Given this list of marker genes ITGA5, AMELY, ATOSB, GLRX, S100A8, LRP3, NTNG1, P2RX1, RHOD, CCND2 (cyclin D2), N4BP2L1, ALDH1A3, PDE2A, EMP3, RBMS3, RAMP1, PRG2, NME3, SERPINE1, LTBR, HYI, GADD45G, CPN2, ALAS2, FGL1, WWC1, TSPAN8, SCAMP5, RRP9, CD6, CCL2, FBP1, ITIH2, CCN5, SERPINA6, ALB, CHGA (NCBI Gene Id 1113), LDLR, MYH2, ETFB, AOC1, STOML1, TNFRSF1B, UGDH, FXYD1, OCLN, LRIT1, WFDC2, DLC1, APCS, PLK3, PRSS8, IVD, HAP1, MYRF, ADH1C, BCKDK, PYGL, SHMT1, FGB, LAIR1, PHYHIP, ITGA10, PDGFRA, JAK3, AQP1, EPAS1, COL1A2, PEG3, ECI1, SLC37A4, COL3A1, CXCL12, AKR1C3, ALDH3A2, PROX1, ADAM19, EFS, GRM2, SLC22A18AS, FGFR4, NR4A1, LECT2, PLIN2, NRGN, GSTT1, CLDN10, PALM, PTPRN, ELL2, S1PR4 (sphingosine-1-phosphate receptor 4), AANAT, TM4SF4, RECQL5, CDK18, MME, NR1D1, SRPK3, ABCC3, DNM2, RAC2, GSTM1, APOC2, SLC7A4, MAL (NCBI Gene Id 4118), TRPC4AP, NECTIN2 (nectin cell adhesion molecule 2), SLC7A8, ETS2, DHRS3, SLC22A6, BDH1, GAGE12F, TDO2, PRB4, COL1A1, LTF, QDPR, COX7A1, CYP27A1, HPD, CLEC3B, ANK3, APLP1, MGP, DVL1, DNASE1, COL18A1, NQO1 (NCBI Gene Id 4834), NNAT, CHRNB4, TYR, ACSL6, PLAT, GNG12, PSD4, GMPR, INSIG1, SRGN, KRT14, SPRY1, NCALD, AADAC, NR0B2, CELA2B, TNFRSF14, MYL9, AZGP1, ATP2A3, CYP2C8, XPNPEP2, PAX6, RGN, UGT2B4, MPO, LBP, TM7SF2, CLCNKA, LRP1, IER3, FEV, DPYSL4, SNCG, GPX3, S100A11, GPX2, ECM1, NFKBIB, SIX6, ESR1, SCG5, APOA1, KCNQ3, CST1, ADRA2C, IL7R, GNMT, SV2A, FMO5, GNG7, LLGL2, KCTD17, TCN2, PLCB2, CDR2L, DDC, RBM38, FURIN, EGR1, PDE4C, PPP4R2, TFR2, HPGD, DBP, TRIM29, FPR2, UBE2C, LCE2B, ZIC2, MFAP2, LYPD3, FBN2, TLE2, KCNN4, F2, CD163, UMOD, AQP7, ALPL, APOA4, RBP4, ADIRF, ANPEP, GCHFR, PSG7, MYH11, ATP11A, H3C6, UGT2B15, SLC17A3, AAK1, LCAT, SLC10A1, IGFBP4 (insulin like growth factor binding protein 4), APOC3, CFHR1, PTPRN2, MGLL, CRYAB, CRIM1, TBR1, IL32, CAV2, AMELX (amelogenin X-linked), SLC22A1, CYP3A7, REG1B, ID2B, SCNN1A, ECHS1, HLA-DMA, DHRS2, PNRC1, ACTN1, TNFRSF6B, APEX2, MSX1, PRSS3, GRIK5, CES1, COL6A1, ACR, SHBG, NEBL, GPT, FADS1, PLEC, ICMT, CRYM, HTR4, MYOG, TPM2, TFAP2A, PFKFB2, SELENOP, TGM2, PHLDA2 (NCBI Gene Id 7262), CYP4F12, RNASE3, ASIP, SLC25A1 (solute carrier family 25 member 1), RND1, TBCD, CPB2, ITGA3, AMBP, COL6A3, APOL1, MUC5B, AMY2B, H4C3, APOD, COL2A1, ABCA1, NCF1C, MAT1A, ODF1, GCG, GPC3, GLYAT, CBS, KRT31, CARD10, PCBD1, RAB31, FMO4, DMBT1, SLC6A2, KRT18, CD14, PAX7, PTPRO, BBOX1, ABCA3, CDK5R1, ATP6V0A1, IL1R1, ABAT, UNC13B, SERPINC1 (serpin family C member 1), LCN2, KCND3, RGS10, ECM2, ITIH4 (NCBI Gene Id 3701), FGFR1 (fibroblast growth factor receptor 1), HSPG2, FN1, MSMO1, PRR4, SGCE, EPHX1, HPN, TMSB4Y, ITIH3, GATM, STARD5, PHLDA1, LMO2, TMEM97, DNASE1L3, ABLIM3, IFIT1, PROC, SLCO2B1, TULP1, ALDOB, ENPP1, MYLK, DPP4, HRG, PPL, ITGA2B, PRELID3A, LEFTY1, AGXT, C1QB, ACP5 (acid phosphatase 5, tartrate resistant), NHERF1, ERBB3, RAC3, DTX4, EDA, PGC, CDC20, PLAU, CEACAM3, MMP2, SDC1, APOE, SERPINA3 (NCBI Gene Id 95022), CLDN7, AQP9, KRT4, WNT10B, EXD2, UBE2L6, SLC1A6 (NCBI Gene Id 6511), MPPED1, BAAT, GJB1, VEGFA, CRYZ, TIMP3, PLA2G2A, REG1A, TCF7, DIO1, HBD, ISG15, SSTR2, FOS, PEPD, SNAP25, HGD, HMGCS2, EPHX2, KLK11, GATA2, AMT, KRT7, ADH1B, FGFR3, SYNGR4, LRRC32, SLC7A11, EPB41L3, FAT1, HBZ, PON3 (NCBI Gene Id 94886), ALPG, NNMT, LRCH4, DDIT4, MSLN, TRIB1, NRTN, ASGR2, GRN, FOXO4, ST6GALNAC4, PTH1R, CFD, GOT1, ELN, RCVRN, HOXB2, CD33, L1CAM, GALNS, CITED2, ARHGDIG, DEFB1, MSMB, PSD, CNKSR1 (connector enhancer of kinase suppressor of Ras 1), PFKFB3, XDH, FOLR1, PRSS2, MTHFS, RHBDL1, CRABP1, C7, PPBP, IKBKG, C8B, FAT2, LAPTM5, IGSF1, SYNPO2L, IQGAP2, RAMP2, SLC38A10, ITGA6 (integrin subunit alpha 6), CCN1, BMP1, MAGI1, GPR17, CRLF1, PLPP2, FGA, MAOB, AMACR, ORM2, HMOX2, KIF21B, PLAAT3, TNFRSF10C, DKK4, DSP, SDS, CYB5R1, CYP4A11, IHH, MUC1, ALDH1L1, NFKBIL1, TM4SF1, ZKSCAN3, CFI, BSN, COL5A2, C1S, TSPAN7, GPR3, CP, CDH4, G0S2, PDZK1IP1, BRD4, ALAS1, PPP1R1A, GFPT2, GRK1, SFRP1, CDC42EP1, DRD2, MTHFR, IGFBP1, SLC4A4, SLC17A7, SPP2, THRA, CYP2F1, CYP2A7, ABLIM1, SERPIND1 (serpin family D member 1), HSPA6, GAS1, EGFR, NAAA, C6, APOC1, CCND1, MEF2C, ARG1, CFB, ELAC2, KCNMB1 (potassium calcium-activated channel subfamily M regulatory beta subunit 1), SPP1, SOX9, C8A, TNXB, PEG10, ALDH7A1, SLC18A3, HAAO, APBB1, GCLC (glutamate-cysteine ligase catalytic subunit), TACC2, CX3CL1 (NCBI Gene Id 6376), CKS2, SOD3, COL4A1, HNF1B, KRT86, KNG1, DNAH3, TGFBR2, XK (X-linked Kx blood group antigen, Kell and VPS13A binding protein), REN, CASP2, DTNB, PLCH2, P4HA1, QPCT, RNASE1, IGFBP3, FZR1, ATF5, PCK1 (NCBI Gene Id 5105), COL7A1, PPP6R2, C5, SRPX, SERPINA5, FCGRT, HSD17B6 (hydroxysteroid 17-beta dehydrogenase 6), MARF1, MT1G, ITGB5, CYP2C19, PIP, MST1, LTC4S, GDF15, STX1A, CHI3L2, FADS2, S100A9, PCLAF, DCAF7, LY6D, CTSG, SOX10, ABCC6, ENPEP, TBC1D2B, NEURL1, BCAM, GSTM5, PER1, PCK2, SLC4A1, CD22, CCL7, HPR, SORD (NCBI Gene Id 6652), UBL3, DAPK2, ETV3, DDT, DLK1, ADH1A, LGMN, HCN3, EFNA1, SMOX, IL3RA, ANGPT1, VGF, CYP2J2, SPINK1, FCN2, CFAP410, SORBS2, GYPB, CDA, APC2, HSD11B1, BARX2, GATA1, CCKAR, PAH, RIBC2, COL6A2, CD55, RBP1, AK4, ACKR1 (atypical chemokine receptor 1 (Duffy blood group)), CSF3R, PIM2, DAO, ZBTB20, SRRM2, KIAA0586, ECE2, SST, NFIL3, DNAJB2, SBNO2, IGF1, HSD11B2, CEP135 (centrosomal protein 135), NRG2 (NCBI Gene Id 9542), PIGO, ARFGAP3 (NCBI Gene Id 26286), CHRNB1, UBXN1, CYP4B1, ACOX2, TRPM2, SELE, IL1RN, GADD45B, CREB3L1, RNASE2, HOMER2, HSPBP1, PTP4A3 (protein tyrosine phosphatase 4A3), TGFBI, ITIH1, BMP10, CCL15, CDH16, YPEL1, PAEP, LDOC1, POU2F2, CRYAA, FAM107A (NCBI Gene Id 50803), FKBP1B, TBX5, VTN, ATP4A, PAX4, UGT2B7, HBEGF, ASGR1, NECAB3, RBMXL2, TIMM17B, FBXL7, CHST3, CST7 (NCBI Gene Id 8530), HYAL1, LAMB2, ADM, CLDN8, SLC16A4, CPS1, EFNA2, C2, IL2RG, APOB, IFI27, RARRES2 (retinoic acid receptor responder 2), FAAH, GNE, SLC2A3, CCNF, AHSG, RIMS2, HP, TM4SF5, NUPR1, DRD3, LIF, IGHG3, SFTPC, AKR1C1, ALDH1A1, RNF167, TCL1A, ZYX (zyxin), INHBC, HSPA2, PTTG1, LGR5, TFF3 (NCBI Gene Id 7033, trefoil factor 3), TRIM15, CYP2E1, LY6G6C, FLT1, PNOC, PINK1, ST6GAL1, EPOR, KRT5, BLVRB, DPH2, FST, CLDN9, KCNJ4, WDR7, TRIM16, MCM2, IGF2, APOC4, AKR7A3, APOH (NCBI Gene Id 350), CYP2B6, FMO3, ENTPD2, SERPINF2, TNFSF10, ATP9A, PRF1, STAB1, FETUB, S100A4, PLG, SIM2, SCN4A, IVL, CDH1, RHOB, ENPP2, ACSL1, JUNB, AGT, GCH1, CFP, SLC7A7, LGALS4, SLPI, VSIG4, IL4R, UCN, C4BPB, GC, GSTA2, IGFBP2, SEZ6L, TRAPPC6A, FABP1 (fatty acid binding protein 1), CA12, HOXB1, PROM1, TBXT (T-box transcription factor T), TGM4, IGHM, COL9A1, CFH, NAT8, ELAVL2, DLEC1, SEMA6C, PTN, NGFR (NCBI Gene Id 4804), GCLM, CADM1, CYB5A, SLC4A3, AQP8, C4BPA, CD24, GAS8, CA2, CLDN3, CA4, APOM, ALDH4A1, TNFRSF25 (NCBI Gene Id 8718), KCNQ1, SMAGP, F10, TFAP2B, TNFRSF10B, CCHCR1, PRSS16, EIF4EBP1, ALDH1B1, AEBP1, DHRS1, HSD17B1, PHYH, MAOA, CEL, TACSTD2, SLC6A11, F12, CLDN5, SERPINA4, CAV1, RNASE4, SLC29A2, GPA33, DEFA3, FXYD2, GALR3, DUSP6, ENG, SCP2, HMOX1, SLC43A1, GTSE1, KRT19, ZBED4, EPCAM, SERPINA1, AQP3, DNM1, AQP5, MMP11, GREM1, PCOLCE, SCO2, H2BC12, NR2E3, AR, here is a description of the gene set: Genes in the cancer module 55. studied in species Homo sapiens Human Gene Set: MODULE_55